Given this list of marker genes CRTAM, CDH10, CDH16, ROBO2, SLITRK3, PTPRR, CLDN18, CDHR1, CLDN5, ROBO3, CDH8, PCDHB3, PCDHGA4, PCDH19, EMB, CDHR5, NEXN, PCDH11Y, MBP, IGSF9, CDH20, PCDHGB2, PLXNB3, CDH19, PCDH20, VCAM1, KIFAP3, PCDHGC3, CEACAM1, PCDHB10, DSCAML1 (NCBI Gene Id 57453), NECTIN3, CADM4, PCDHGA9 (NCBI Gene Id 56107), PTK7, PCDHAC2, CDH9, AMIGO3, PALLD, PCDHGA6, PIK3CB, MAPK7, CDH3 (NCBI Gene Id 1001), DCHS2, UNC5D, SCARF2, PCDH10, PKD1, LRFN4, FXYD5, PCDHGB5, NTNG1, LRRC4C, KIRREL3, CDH26, IL1RAP, CRB2, AMIGO2, CD6, MIR221, PCDHB13, PCDHB8, MYPN, NRXN1, LRRC4B, MPZ, WNK1, PTPRS, PVR, CLDN6, PCDHGA1, CLDN1, PCDHGB4, CEACAM6, CDH1, RET, MPZL2, PCDHGA2, PCDHA8 (protocadherin alpha 8), MMP24, TRO, PCDHA3 (protocadherin alpha 3), DSC3, FAT2 (NCBI Gene Id 2196), CEACAM8, ITGAM, CLDN2, GPC4, CDH4, CLDN9, PCDHGA3, CDH18, PTPRM, IL1RN (NCBI Gene Id 3557), SDK2, SLITRK1, ITGA3, CDHR3, HMCN2, PCDHB4, CXADR, IGSF11, PCDHGC4, ROBO4, CDH12, CBLN1, PCDHGB7, ELFN2, PCDHA11, CNTN6, CDH24, PECAM1, CLDN7, CELSR1, FLRT3, PCDHA13, PCDH1, PCDHA9, CPLANE2, PCDHA1, LRRC4, MDGA1, CDHR2, CDH11, CLDN17, LRFN5, CD164, DSG3, DSG1, PCDHA10, PCDHGA8, PCDHGA11, TENM4, PCDH15, CD177, PCDHB14, ROBO1, RIC8A, SLITRK5 (NCBI Gene Id 26050), PCDHA4, NECTIN2, CELSR3, CLDN22, CADM3, PTPRG, DAB1, DSC1, DSG4, CDHR4, CLSTN1 (NCBI Gene Id 22883), CDH22, MAPK14, PCDHB2, ELFN1, AJUBA, LRFN3, FGFRL1, PCDHGC5, SDK1 (NCBI Gene Id 221935), FAT4, CLDN8, PSG5, CLSTN3, TGFB2, CNTN4, CLDN12, SPARCL1, ACVR1, PCDHGB3, CLDN15, SELL, DSC2, PCDHB5, PCDHB15, CNTN2, REG3A, ALCAM, CDH17, AMIGO1, FAT3, CDH7, PCDHB18P, HMCN1, PTPRT, CD84 (NCBI Gene Id 8832), CRB1, MAP2K5, L1CAM, CADM2, CELSR2, ITGB2, ITGB1, CLDN3, PCDHB6, CLDN4, JAML, PCDHGA7, UMOD (uromodulin), PCDHB16, APOA1, LGALS7B, TENM3, PCDHA6, CLDN23, PCDHB1, CADM1, SELP, DCHS1, PSG2, CEACAM5, PCDHAC1, CDH2, CDH5, PCDHGA12, FAT1, ATP2C1, CDH6, NTNG2, DSCAM, ADGRL3, CD209, PCDH9, CX3CL1, PCDHB11, MYOT, ESAM, CLDN20, PCDHB12, IL10, SLITRK2, PCDHA2, MAG, NECTIN4, ITGAL, PCDH8, GRID2, PCDHA7, PCDH7, PTPN23, PCDHGA5, ADIPOQ, PCDH18, CLDN16, PCDH11X, CDH13, PCDHB9, CLDN14, PCDHGB6, SCARF1, PTPRD, PCDHA5, PTPRF (NCBI Gene Id 5792), CDH15, PCDH12, CLDN10, BSG, GATA5, KLF4, PCDH17, PCDHGB1, PCDHA12, NECTIN1, CLSTN2, CDH23, TGFBR2, CLDN11, NPTN, IGSF21, IL1RAPL1, MYADM (NCBI Gene Id 91663), BMP2, DSG2, NLGN1, PLXNB2, ITGA5, CLDN19, SELE, PCDHGA10, PCDHB7, EFNA5, ICAM1, PSG11, here is a description of the gene set: Human Gene Set: GOBP_CELL_CELL_ADHESION_VIA_PLASMA_MEMBRANE_ADHESION_MOLECULES The attachment of one cell to another cell via adhesion molecules that are at least partially embedded in the plasma membrane. species: Homo sapiens